Given this list of marker genes SCNN1A, SCNN1D, SCNN1B, SCNN1G, CALHM1 (calcium homeostasis modulator 1), CALHM3, here is a description of the gene set: Human Gene Set: REACTOME_SENSORY_PERCEPTION_OF_SALTY_TASTE species: Homo sapiens Sensory perception of salty taste